The following is a description of a gene set: studied in species Homo sapiens Human Gene Set: GSE25123_IL4_VS_IL4_AND_ROSIGLITAZONE_STIM_MACROPHAGE_DAY10_UP from publication Szanto A, Balint BL, Nagy ZS, Barta E, Dezso B, Pap A, Szeles L, Poliska S, Oros M, Evans RM, Barak Y, Schwabe J, Nagy L (PMID 21093321) Genes up-regulated in wildtype bone marrow-derived macrophages treated with IL4: control versus rosiglitazone. Conditional macrophage-specific PPARg knockout mice were generated on C57Bl/6 background by breeding PPARg fl/- (one allele is floxed, the other is null) and lysozyme Cre transgenic mice. PPARg and IL-4 signaling was analyzed on bone marrow-derived macrophages. Bone marrow of 3 mice per group was isolated and differentiated to macrophages with M-CSF (20 ng/ml). 20 ng/ml IL-4 was used to induce alternative macrophage activation and 1 uM Rosiglitazone (RSG) was used to activate PPARg. From each mouse 4 samples were generated: 1. M-CSF, 2. M-CSF+RSG, 3. IL-4 and 4. IL-4+RSG. All compounds were added throughout the whole differentiation process, and fresh media was added every other day. Control cells were treated with vehicle (DMSO:ethanol). After 10 days, RNA was isolated and gene expression profiles were analyzed using Mouse Genome 430 2.0 microarrays from Affymetrix., and this is the list of marker genes: FUT7, SYNPO, SLAMF6, PTPN13, ZCCHC18, PLXNC1, TOP2A, CLDN12, SNX7, PLK3, GPR68, TMBIM1, IL1R1, KLRG1, PPFIBP1, ANGPTL2, RAB11FIP3, B4GALNT4, CAPG, AREG, CCDC102A, CD81, IL21, ST14, UNC119, AHR, CCHCR1, CRELD2, FAM210B, RXRA, CDC25B, NEURL1B, ATF6, ENDOD1, DUT, RNASE4, EHBP1L1, SNX33, GINS1, FAM20A, WDR26, ARL14, MAP3K8, IFT43, BUB1B, ID2, TJP2, TOX2, GDPD5, NEB, CDKN2C, PENK, ZAN, PDCD1, LGMN, CRMP1, NLN, EPDR1, RAB19, RHOC, IGSF9B, SLC39A4, FUCA2, ARNT2, ATOSB, PPP1R16B, BTBD3, NHSL2, CXCR5, DUSP5, NUCB1, RNF128, MAPK12 (NCBI Gene Id 6300), SPAG5 (NCBI Gene Id 10615), POGLUT3 (protein O-glucosyltransferase 3), AMOTL1, DTL, KDELR2, CRYBG3, ITGAV, KRT18, CD38, GCNT1, FARP1, UBASH3B, MAPK11, EHD4, CYSLTR1, BRCA1, PTPN3, CASS4, MMD, NCMAP, KIF4A, ALAD, SLC25A24, CD74, S100A6, ANXA4, SLC22A15, MPPED2, SPP1, OSBPL3, TIRAP, ITGAE, NRP1, HHEX, LITAF, NCKAP1, TNFRSF9, EEA1, MATN2, ROM1, RILPL2, SNRNP25, PLEKHA8, PLEKHG3, SNAI2, NID2, SOSTDC1, SAMSN1, TTC22, GPR15, NPR1, LGALS1, GZMB, SERPINB1, CAMK1, GNA15, TNFSF11, MYO1F, IFITM2, DHRS3 (dehydrogenase/reductase 3), CDKN2B, MED7, TNFRSF4, HGFAC, GPR20, PDLIM7, PAQR3, TNFSF8, VMP1, LPAR3, IL10RB, TBCB, CASP3 (caspase 3), CHST11, SRGN, STX11, NFATC1 (NCBI Gene Id 4772), TRPM6, KRT5, LGALS3, CCR2, IDH3A, MALT1, SPDL1, ASB2, TDRD7, CAMK2A, IL1R2, SAMD11, STOX1 (NCBI Gene Id 219736), PLSCR1, RUNX2, WEE1 (WEE1 G2 checkpoint kinase), BID, PCOLCE2, SAMD10 (sterile alpha motif domain containing 10), ARPC1A, ADAP1, CST7, SKAP2, IL1RL1, SLC2A8, BCL2A1, PLEKHH3, RORC, S100A11, WASHC5, ZNF821, IGKC, VDR, CASP1, TNFSF14, ID3, CYP51A1, KNTC1, KCTD17, SLC15A3, ACYP2, CXXC5, PGLYRP1, EPHA6, NFIL3, ABHD4, MKI67, VPS54, GBP4 (NCBI Gene Id 115361), LYN